The following is a description of a gene set: Mouse Gene Set: GOBP_REGULATION_OF_TELOMERE_MAINTENANCE Any process that modulates the frequency, rate or extent of a process that affects and monitors the activity of telomeric proteins and the length of telomeric DNA. species: Mus musculus, and this is the list of marker genes: Pinx1, Nfrkb, Prkcq, Ctc1, Nek2, Upf1, Ptges3, Pkib, Pif1, Map3k4, Actr8, Atm, Uchl5, Ercc4, Hdac8, Terc, Tent4b, Bmyc, Ppp1r10, Ruvbl1, Ankrd66 (ankyrin repeat domain 66), Nbn, Exosc10, Acd, Gnl3l, Parp1, Xrcc1, Tinf2, Wnt3a, Xrcc5, Tfpt, Nabp2, Hnrnpu, Tcp1, Pnkp, Terf2ip, Smg1, Cct5, Parn, Terf1, Wrap53, Ruvbl2, Stn1, Gch1, Klf4 (NCBI Gene Id 269540), Rtel1, Ercc1, Dcp2, Tnks2, Ylpm1, Hnrnpc, Smg6, Dhx36, Rad50, Myc, Mre11a, Ino80b (INO80 complex subunit B), Fbxo4, Cct3, Hnrnpa2b1, Cct8, Atrx, Nek7, Naf1 (NCBI Gene Id 277960), Hnrnpd, Mapk15, Mcrs1, Smg5, Hmbox1, Potefam3b, Mapk3, Dkc1, Actl6a, Pot1a, Trp53, Ctnnb1, Tnks, Gnl3, Yy1, Mapk1, Pml (promyelocytic leukemia), Mapkapk5, Cct6a, Pot1b, Cct2, Ino80d, Potefam3a, Nat10, Map2k7, Ino80, Cct7, Terf2, Aurkb, Src, Sirt6, Ten1, Slx1b, Actr5, Ino80c, Nvl, Xrcc4, Cct4, Atr, Lmna (NCBI Gene Id 16905), Slx4 (SLX4 structure-specific endonuclease subunit homolog (S. cerevisiae))